Given this list of marker genes Tgm2, Fgf8, Clcn2, Fgf10, Nkx3-1, Snai2, Nfib (nuclear factor I/B), Dag1, Xbp1, Plxna1, Edar, Fgf7, Esrp2, Cdh1, Ctnnd1, Ntn4, Btbd7, Shh, Sema3a, Fgfr1, Nrp1, Muc19, Fgfr2, Sema3c, Polb, Plxnd1, Tgfb1, Hgf, Egfr, Tnf, Tfcp2l1, Esrp1, Lama1, Pdgfa, Pax6, Bmp7, Ascl3, Met, Twsg1, Tgfb2, Pdgfb, Il6, Eda, Cdc42, Lama5, Tgfb3, here is a description of the gene set: Mouse Gene Set: GOBP_SALIVARY_GLAND_DEVELOPMENT studied in species Mus musculus The process whose specific outcome is the progression of the salivary gland over time, from its formation to the mature structure. Salivary glands include any of the saliva-secreting exocrine glands of the oral cavity.